Given this list of marker genes ZNF98, CNR1, TRMT10C, TRIM71, TENT2, EHMT1, OPN5, TBCK, KLHL1, SDC2, NOG (NCBI Gene Id 9241), HOXC4, SULF1, OSBPL11, MID2 (NCBI Gene Id 286440), RRP8, FABP2, KHSRP, BEND6, SERAC1, RORA (NCBI Gene Id 6095), ENO4, THEMIS, LHFPL2, DLG3, IL1RAP, PALM2AKAP2, DAAM1, FCGR2B, IRAK1BP1, SUB1, BBOF1, TNRC6B, ARMC8, KANK2, ITGA7, ATXN7, KLHL18, SLC1A2, ARG2, CORO1C, PKN2, MAP2K5, FAM89A, CYLD, UQCRB, SRGAP3, ACP3, SNX9, PCDH7, TNS1, PRMT8, ANAPC10, XPNPEP1, HRH4, POLR3B, EPPIN-WFDC6, PURG, ZNF275, PKD2, TMEM144, MTHFR, CDH12, TUBGCP4, TAL1, MSX1, ZNF704, ZBTB10, PLCD4, ZNF281, CNTN5 (contactin 5), TLCD4, PDE10A, KIAA1191, MATN3 (matrilin 3), RAB33B, PRKD1, MBNL1, NR4A3, ZNF492, ABCD3, VLDLR, CHN2, RETREG3, LAMP2, QKI, EMC4, SLC25A30, MMGT1, DNAJC11, GUCY1A2, VCF1, UHRF2, ZC3H12D, YWHAG, MICOS10, PTBP3, DEFB132, LARGE1, CLSTN2, EIF2S1, NFIB, YTHDF2, MSL2, XXYLT1, UBR5, PHLDA1, CNTNAP4, NEGR1 (neuronal growth regulator 1, NCBI Gene Id 257194), here is a description of the gene set: Genes predicted to be targets of miRBase v22 microRNA hsa-miR-4273 in miRDB v6.0 with MirTarget v4 prediction scores > 80 (high confidence targets). species: Homo sapiens from publication Chen Y, Wang X (PMID 31504780) Human Gene Set: MIR4273